Given this list of marker genes Rnf168, Rubcn, E130310I04Rik, Kalrn, Fbxo40, Ccdc14, Stfa1, 1700119H24Rik, Gm41467, n-R5s33, Pdia5, Hcls1, Dynlt2b, Smco1, Csta2, Hacd2, Fstl1, Mylk, Stfa2, Gm24437, Rpl35a, 2210020O09Rik, 1600019K03Rik, Gm25079, Gm8425, Lrch3, Gm34680, Gm5963, Ubxn7, Mir1947, Gm26838, Zdhhc19, Gtf2e1, Lmln, Wdr5b (NCBI Gene Id 69544), Dtx3l, Cox17, Itgb5, Slc49a4, Gm8538, Cstdc6, 4930565N06Rik, Fam162a, Tfrc, Rabl3, Iqcb1, Cstdc3, Parp14 (poly (ADP-ribose) polymerase family, member 14), Stxbp5l, Parp9, Kpna1, Ndufb4, Gm25140, Nr1i2, Pcyt1a, Fyttd1, Muc13, 1700007L15Rik, Polq, Btnl12, Cfap91, Csta1, Cstdc4, Slc51a, Gm10913, 2600002D14Rik, Gm8387, Cstdc5, Ropn1, Golgb1, Gm4600, Hgd, Casr, Gm15665, Mix23, Lrrc58, Stfa2l1, Gm15725, Tm4sf19, Zfp148, Gm21691, Gm23080, Eaf2 (NCBI Gene Id 106389), Gm5405, Gpr156, Tnk2os, Slc15a2, Ildr1, Gm46559, Sema5b, Csta3, Hspbap1, Gm20056, Gm15564, Gm9556, Stfa3, Heg1, Gm10237, Gm7260, Umps, Tnk2, Gsk3b, Smbd1, Gm6611, Iqcg, Sec22a, Gm25967, Gm23518, Adcy5, Osbpl11, Gm34967, Snx4, Gm25903, Gm6815, Muc20 (mucin 20), Cd86 (CD86 antigen), Gm49663, Slc12a8, here is a description of the gene set: species: Mus musculus Mouse Gene Set: chr16B3